The following is a description of a gene set: Human Gene Set: GOBP_PHOSPHATIDIC_ACID_METABOLIC_PROCESS The chemical reactions and pathways involving phosphatidic acid, any derivative of glycerol phosphate in which both the remaining hydroxyl groups of the glycerol moiety are esterified with fatty acids. species: Homo sapiens, and this is the list of marker genes: DGKK, PLD1, ACP6, PLA2G2A, DGKE, GPAT3, DGKG, GPAT4, AGPAT3, DGKA, ABHD8, DGKI, GPAT2, DGKB, ABHD4, PLA2G3, LPCAT1, PLA2G6 (phospholipase A2 group VI), PLD2 (NCBI Gene Id 5338), AGPAT4, AGPAT5, LPCAT4, LIPH, DGKZ, PNPLA3, GPAM, PLA2G10, ABHD5, AGPAT1, AGPAT2 (NCBI Gene Id 681), NR1H4, LPIN1, DGKH, DGKD, GNPAT, DGKQ, SH3GLB1, LCLAT1, LIPI